The following is a description of a gene set: Human Gene Set: HP_ABNORMALITY_OF_THYROID_PHYSIOLOGY Abnormality of thyroid physiology studied in species Homo sapiens An abnormal functionality of the thyroid gland., and this is the list of marker genes: MSTO1, MT-ATP8, ABCC8, ADAT3, KCNJ11, MT-TL2, SUGCT, INSR, MT-ND5, TONSL (tonsoku like, DNA repair protein), MLXIPL, SCLT1, RAG2, SKI, NODAL, IFT172 (intraflagellar transport 172), MT-ND1 (mitochondrially encoded NADH:ubiquinone oxidoreductase core subunit 1), NNT, RNASEH2A, RBM28, BBS7, MT-TW, CYP27A1, BBS2, RPL10, TBL1X, GNB1, NCF1, CASZ1, WDPCP, SLC37A4, FOXN1, RNU4-2, GNAQ, RNU7-1, BBS10, GLI3, PMM2, PDPN, ATPAF2, FGF13, METTL27, TWNK, MT-TF, SETBP1 (NCBI Gene Id 284262), GPR101, ALG2, SPOP, MPI, PLAG1, MC2R, PRKCZ, ARL6, TSHR, FARSA, AFF4, ABCB4, SMARCE1, TRHR, NEXMIF, MYT1L, XRCC4, CTNS, PTEN, KARS1, STUB1, ATP5F1D, MAGEL2, KCNAB2, RAG1, BMP6, JMJD1C, TSC1, ADA, HID1, PDCD1, SIX3 (NCBI Gene Id 6496), KCNJ10, HBB (hemoglobin subunit beta), THRB, CRIPTO, TRAPPC9, DYRK1A, B3GLCT, STAT3, FOXA2, WDR4 (WD repeat domain 4), SLC6A17, KCNJ2, CPE, SMO, RMRP, TMEM270, BUB3, TTR, PRIM1, BAP1, SCN4A, CEP19, PRDM16, NR1H4, DCLRE1C, ANAPC1, SLC26A4, WDR11, B4GALT1, STAG2, ZFP57, CRELD1, GLIS3, LRBA, NDN (necdin, MAGE family member), GTF2IRD2, SLC5A5, NKX2-1, DNAJC30, ALX4, IL2RG, MDM4, POMC, LZTFL1, SAMHD1, GLI2, MKKS, EIF4H, GAS1, CLCNKB, ABCB11, GTF2I, BBS9, GCH1, ADAMTSL1, UFD1, SLC25A4, APC2, FOXH1, PDE4D (phosphodiesterase 4D), IFT27, KEAP1, TIAM1, SCAPER, MADD, SNRPN, FOXP1, TBC1D24, BBS5, WFS1, GABRD, TBL2, POLR3A, PTCH1, MT-CO1 (NCBI Gene Id 4512), ZIC2, TRMT10A, IL6ST, FUT8, GP1BB, LHX4 (LIM homeobox 4), IRS4, FUCA1, RRM2B, CFAP418, BBS4, ROBO1, ARVCF, PAX8, ATP8B1, FANCI, MKS1, SRY, TTC8, STAR, PNPLA6, ZBTB20, CCDC47, TGIF1, SGPL1, POLG2, CHD7, SLC12A3, SASH3, POU3F4, ATP11A, TF, DNM1L, SKIC3, SOX3, LIMK1, GABRA3, CACNA1C, ELN, TPO, MT-TQ, LIG4, KCNJ18, CLIP2, USP9X, LIFR, MCM8, HGD, RERE, BUD23, SUPT16H, MT-ND6, MT-ND4, DDB1, C1QBP, YRDC, MPV17, MT-TL1, IFT74, TSC2, MT-TS2, HNF1B, NR4A2, ATP5MK, CACNA1S, DNA2, AKT1, SLF2, PLAGL1, NSD1, PLVAP, VPS37D, TRIP13, GRIA1, FLII, SLC25A36, HNRNPK, HLA-DRB1, DLL1, RAI1, GRIN2B, SIM1, IYD, IL2RA, KMT2D, PCSK1 (proprotein convertase subtilisin/kexin type 1), TSHB, KAT6B (lysine acetyltransferase 6B), PTRH2, THRA, SMARCAL1, ITCH, CNBP, TBX1, SLC16A2, HIRA, EIF2AK3, APOE, RNASEH2B, BICRA, CBLB, UBE4B, DDOST, IFIH1, GYG1, CDH23, LEP, MARS1, STEAP3, FMR1, TXNRD2, KANSL1, AIRE, ALMS1, BUB1, COMT, TG, TREX1, TBCK, DNAH1, SUFU, SMC1A, FOCAD, TRH, DUOXA2, RFC2, STX1A, POU1F1, JAK1, ATP5F1E, GNAS, ADAR, RREB1, POLG, HSD17B3 (hydroxysteroid 17-beta dehydrogenase 3), TERT, ATP6V1B2, OCA2, MT-ATP6, SALL1, IL7R, PLAA, TMEM67, TRAF7, GNA11 (G protein subunit alpha 11), BRAF, MT-CO2, UBR1, GRM7, IFNG, LSM11, IPO8, SMARCB1, NPHS1, PRKAR1A, DIO1, FOXE1, STIL, HYMAI, ASH1L, FOXP3, APC, CDKN1B, BTNL2, DACT1, TRIM32, KDM6A, YY1, KISS1R, CD55 (CD55 molecule (Cromer blood group)), SECISBP2, FGF8, LUZP1, IQSEC2, BCOR, FDX2, ALB, SEC24C, LEPR, CLPB, ACP5, CREBBP, MTTP, NKX2-5, PIK3C2A, SVBP, IGF2, LRP4, PROKR2, MRAP, PLAAT3, ARL6IP6, DNAJC19, ADCY5, NF2, EXT2, GPR161, CEP57, PIK3CA, DMXL2, IRF4, CDON, ALG8, POLR3GL, LHX3, SDCCAG8, FKBP6, MEN1, SHH, BUB1B, SPEN, HDAC4, MT-TH, HESX1, CEP290, KATNIP, KMT2B, OTX2, PLCH1, FGFR1, MT-CO3, ATP5F1A, HMGA2, DEAF1, DICER1, GATA4, FLCN, KLF1, PIEZO1, IMPDH2, OPA1 (OPA1 mitochondrial dynamin like GTPase), SRD5A3, PROP1, BAZ1B, GNE, GATA6, PDGFB, NIN, BBS1, MT-TN, TANGO2, MMP23B, DUOX2, PPP1R15B (NCBI Gene Id 84919), UBR7, FOXI1, BMP4, HSPG2, ZFX, EXOSC2, BBS12, CDKN1C, NPHP1, PHF21A, DISP1, HPD, AIP, HFE, SAA1, GTF2IRD1, ARNT2, MOGS, SKIC2, RNASEH2C, CTNNB1 (catenin beta 1), CHD8, BBIP1, CHD6, STAT1, IGSF1